The following is a description of a gene set: part of: ATP-dependent chromatin remodelers Mammalian CHD complexes are ATP-dependent chromatin remodelers that have one of nine chromodomain and helicase-like domain (CHD) proteins providing the catalytic ATPase and DNA translocase functions. In addition to the SNF2/helicase C ATPase domain, human CHD proteins are characterized by two N-terminal chromodomains that interact with methylated histone tails, a 'NegC' domain that negatively regulates the ATPase domain, and, in some cases, a C-terminal DNA-binding domain. CHD family members are implicated in regulation of nucleosome assembly and spacing, repositioning and nucleosome editing.<br>CHD proteins are grouped into three subfamilies based on their other domains and mode of action.<br>Human CHD1 and CHD2, neither of which is very well studied, are part of Subfamily I. Members of this family have an N-terminal DNA binding region that preferentially interacts with AT-rich DNA. Based on studies in S. cerevisiae, which has a single CHD protein, CHD1, subfamily 1 members appear to function as monomeric or dimeric ATPases, and may additionally interact with CHD2. Human CHD1 has been shown to bind to H3K4 marks and may function in transcriptional activation.<br>Human CHD3, CHD4 and CHD5 are part of Subfamily II and are characterized by the presence of two plant homeodomains (PHD), zinc finger-like domains that have been shown to bind to trimethylated histones. CHD3, 4 and 5 all participate as the ATPase component of distinct NuRD (nucleosome remodeling deacetylase) complexes that couple ATP-dependent nucleosome remodeling with histone deacetylase activity. <br>Human CHD6, CHD7, CHD8 and CHD9 are part of Subfamily III and are orthologs of the Drosophila Kismet enzyme. Subfamily III CHD proteins are characterized by the presence of SANT and BRK (Brahma Kismet) domains, both commonly found in proteins involved in histone binding and chromatin remodeling. Human Subfamily III members have been shown to act as both transcriptional co-activators and co-repressors.<br> species: Homo sapiens Reactome Pathway: CHD chromatin remodelers, and this is the list of marker genes: SNRPD2, CDK2AP2, H2BC4, CHD9, WDR5, SNRPN, DDX42, CHD8, CHERP, GATAD2B, ZNF687, UBE2I, DKK2, IGF2, CHD3, PHF5A, CREBBP, ZMYND8, SNRPB, MTA2, H2AC7, CHD5, CHD6, SNRPD1, H2BC17, CBX3, U2SURP, PB1, SNRPE, HDAC2, CDC73, NFE2L2, PAF1, NS, CBX1, H2BC9, MYOD1, IKZF2, PB2, H2BC5, MTA3 (metastasis associated 1 family member 3), SKIC8, H2AZ2, SF3B6, DDX46, CTCF, LEO1, SSRP1 (NCBI Gene Id 6749), H3C15, H2AB1, SF3B1, SNRPD3, ZNF532, SF3A2 (NCBI Gene Id 8175), H2BC13, MBD3L2, TCF12, H2AX, MTA1, SNRPF, G6PC1, CTNNB1 (catenin beta 1), PWWP2B, H3-3A (NCBI Gene Id 3020), SF3B2, NR2F2, H2AC18, H2AC14, SUPT16H, TCF19, CTR9, SNRPA1, IKZF1, H2BC1, ADNP2, H2BC12L, SF3B4, FAM124B, PHF6, PA, AXIN2, SNRPB2, PCK1, NR2C2, CHD2, IKZF3, PUF60, PWWP2A, DHX15, H2AC6, SF3B5, NKD2, RBBP7, H2BC3, MBD2, SNRPG, EP300, H2BC12, MAFK (NCBI Gene Id 7975), CDK2AP1, H2BC26, FBP1, H2AC20, SUMO1, SF3A1, H2BC15, CHD7, CHD4, H4C1, HDAC1, ADNP, H2BC11, SF3A3, TCF3, MBD3L1, RBM17, H2AJ, MBD3 (methyl-CpG binding domain protein 3), NQO1 (NAD(P)H quinone dehydrogenase 1), H2BC14, H2BC21, SF3B3, H3C1, RBBP4, ZNF827, CHD1, SMNDC1, GATAD2A, MYOG, NP, TCF4, ZNF592, H2AC4, RTF1